The following is a description of a gene set: Human Gene Set: REACTOME_SIGNALING_BY_NUCLEAR_RECEPTORS species: Homo sapiens Signaling by Nuclear Receptors, and this is the list of marker genes: H3C8, H2AC18, ESR2, ZDHHC21, TBL1X, ALDH1A1, KANK1, PPP5C, MAPK1, KPNA2 (karyopherin subunit alpha 2), TNRC6C, ALDH8A1, H2BC11, FOXO3, CBFB, AGO4, AKT3, RDH13, SP1, DHRS3, AGO2, TGFA, APOC2, HDAC3, GPS2, RDH16, H4C9, DHRS4, DLAT, MYLIP, H2AC19, GNAI2, BTC, H3C7, H2BC5, PDK4, TNRC6A, PIK3R1, H3C14, AGO1, DHRS9, POLR2G, NRIP1, H4C8, PDHB, EGF, TFF3, H2AJ, IGF1R, H2BC21, CRABP2, H2AC4, APOC4, STAG1, H2BC12L, DDX5, H3C15, PDHX, ANGPTL3, STRN, ATF2, GATA3, NRAS, GPAM, APOD, PTGES3, MED1, PIK3R2, ADH1A, STAG2, MMP9, NCOR1, KRAS, POLR2F, GNAT3, APOE, NCOA1, GNG12, MMP2, GNG5, SRC, PDK2, TLE3, POU2F1, GNAI1, ABCG8, H2BC7, AGO3, APOC1, CXXC5, RAD21, ALDH1A2, TNRC6B, ELK1, GNB3, ZNF217, H2BC9 (NCBI Gene Id 8345), H4C5, GNG11, H3C4, HSP90AB1, H4C11, H2BC17 (H2B clustered histone 17), CCNT1, BCL2, ABCA1, GNGT1, H2AB1, CREBBP, H3C6, GNG8, PDHA1, CXCL12, PDK3, GNG10, CARM1, GNB1, RUNX1, MMP3, H3C3, H3C10, H2AX, SRF, GTF2F2, GNGT2, CDKN1B, CAV1, GNB5, PDPK1, RARA, PLTP, POLR2H, KDM3A, MMP7, CDK9, H4C16 (NCBI Gene Id 121504), FKBP4, H4C14, KDM1A, SHC1, USF1, POLR2D, H4C4, H2BC12, XPO1, JUN, ARL4C, AKR1C3, H2BC13, H2AC14, H2BC10, UHMK1, PIK3R3, GNG7, TBL1XR1, RDH11, POLR2A, CYP26A1, FASN, H2AC6, MYB, PTK2, NR5A2, HRAS, H2BC3, USF2, H3-3A, RDH5, ADH1C, FABP5, POLR2I, POLR2J, H4C15, NCOR2, PCK1, JUND, ERBB4, KDM1B, SDR16C5, H2BC1, RXRG, ZDHHC7, CITED1, PIK3CA (phosphatidylinositol-4,5-bisphosphate 3-kinase catalytic subunit alpha), H4C13, PLIN1, ALDH1A3, CCND1, CTSD, HBEGF, PGR (progesterone receptor), NR1H3, NCOA2, RARG, H3C1, FOS, PDHA2, H3C11, TFF1, H4C12, PPARD, EEPD1, EP300, CHD1, EPGN, MOV10, POLR2B, SMC1A, FOSB, RXRB, H4C2, GNAI3, KAT5, CAV2, CREB1, RDH14, H2BC15, RARB, H2BC26 (H2B clustered histone 26), H4C1, H3C12, FOXA1, PDK1, ESR1 (estrogen receptor 1), POLR2C, GNG4, POLR2K, GNB2, EGFR, GNG3, CETP, H4C3, HSP90AA1, NCOA3, GTF2A1, GNG13, MYC, KCTD6, YY1, CYP26C1, H3C13, GNB4, GREB1, PRMT1, GTF2F1, H4C6, ADH4, AXIN1 (NCBI Gene Id 8312), KDM4B (NCBI Gene Id 23030), CRABP1, SREBF1, H3C2, AKT2, UGT1A3, POLR2E, SPHK1, EBAG9, ABCG1, RDH10, ABCG5, TBP, POLR2L, H2BC4, EREG, FKBP5, H2BC6 (H2B clustered histone 6), NR1H2, PPID, DLD, NOS3, MAPK3, H2AC7, SCD, H2AC8, H2AC20, KDM4A, SMC3, AREG, GTF2A2, AKT1, HSPB1, PRKCZ, FABP6, CYP26B1, GNG2, RXRA, KAT2B, CALM1 (NCBI Gene Id 801), S1PR3, H2BC8, H2BC14, H2AZ2, H3-3B, HDAC1